Given this list of marker genes RHOQ, FSHB, ECE1, BST1, XAF1, SCN1A, GUCY2C, PPIH, ESS2, HEATR6, IGFBP7 (NCBI Gene Id 3490), MTDH, CA4, CACNA1H, AIF1, ANKRD12, SUMF1, ULBP1, THAP4, PI4K2B, AGTRAP, PSMD10, RB1, ERGIC1, LYNX1, CCND2 (NCBI Gene Id 894), ANKRD50 (NCBI Gene Id 57182), TIMM8B, CFP, RTN4RL1, TBC1D12, PPM1J, MTLN, IFNLR1, GTPBP3, RNF125, PPP1R15A, CD177, RIPOR3, MEX3B, PIGZ, POLRMT, RUNDC3B, CCDC88B, ETV1, NRIP1, FYB1 (NCBI Gene Id 55458), TNFSF14, SLC39A4, SPTA1, COL4A1 (collagen type IV alpha 1 chain), NTAN1, VAMP7, IGLC7, NDUFA6, SESN3, ORM2, FKBP7, IL12A, CFH, ECPAS, HNF4G, H2AJ, CYB5R3, FLNC, HDAC9, TMEM60, CHST7, TEX19, ABHD17B, COL14A1, AMMECR1L (NCBI Gene Id 83607), CDK13, TNFSF13B, TMEM223, DECR2, LRMDA, RTRAF, GCNT2, ZCRB1, ALDH1L2, NIPSNAP1, DYNLT1 (dynein light chain Tctex-type 1), DCN, SRGAP1, AMACR, HRG, HS6ST2, ZMYND15, TMEM45A, DTX2, FKBP14, STAB1, VGLL3, CXCL6, RPL22, ENO1, FCGR2B (Fc gamma receptor IIb), MYOM3, PBXIP1, ST3GAL1, C3, C3orf70, GBP6, C19orf81, RETN, COX19, CRABP1, MKI67, AZIN2, IRS2, PIK3CG, ITGA7, ANKRD37, HOXB4, ZNF654, ROBO1, CCSER1, TMEM239, SLPI (NCBI Gene Id 6590), SLC30A9, SMOX, ADAM9 (ADAM metallopeptidase domain 9), COX8A, MAGED1, PTPN2, MFSD2B, XKR8, CHCHD7, SLC1A2, PM20D1, SDF4, COL1A1, HK2, SCN7A, CD72, DOK5, LPCAT2 (lysophosphatidylcholine acyltransferase 2), TTC13, RPE, ROM1, TMEM125, MMP10, EGLN3, TMEM119, MRPS24, PRSS23, CFLAR, CPD, ADGB, H1-10, NCAM1, PYCR2, ISG15, ZNF322, THADA, IFT27, MYL6, RNF114, REEP1, GREM2, CKS2, PLAT, SCARF1, GALNT2, CST7, SAPCD1, CCN3, VPS36, EAF2, AVPI1, C1QB, RPL22L1, CDC16, TNNC1, SLC24A3, SAA2, UNC5C, MEDAG, RPS25, CDH26, STAT1, NDUFA2, SNAPC5, SCRN3, F13A1, SLC25A18, HOOK2, SLC35F1, SLC15A3, FSTL1, ZBTB8OS, ZFPL1, GNAZ (NCBI Gene Id 2781), TMEM33, ZNF808, EIF4E3, KIAA1549, IL4R, PICALM, here is a description of the gene set: Human Gene Set: GSE2585_CTEC_VS_THYMIC_MACROPHAGE_UP from publication Derbinski J, Gäbler J, Brors B, Tierling S, Jonnakuty S, Hergenhahn M, Peltonen L, Walter J, Kyewski B (PMID 15983066) Genes up-regulated in cortical thymic epithelial cells (cTEC) versus thymic macrophages. studied in species Homo sapiens Gene expression in different thymic stromal cells and subsets thereof was analyzed in 6-12 week old wild type (C57BL/6) and Aire knock-out (mixed background) mice. Thymic stromal cells were purified by sequential enzymatic digestion (collagenase, collagenase/dispase and trypsin) followed by gradient centrifugation and FACS sorting. Sort criteria were as follows: dendritic cells (CD11c+, F4/80 -), macrophages (F4/80+, CD11c-), cTECs (CD45–/lo, CDR1/Ly51+, Ep-CAM+) and mTECs (CD45–/lo, CDR1/Ly51–, Ep-CAM+). mTECs of wild-type and Aire knock-out mice were further subdivided according to CD80 expression levels. For microarray analysis total RNA from thymic stromal cell samples of two independent experiments was pre-amplified and biotinylated by two rounds of cDNA synthesis and in vitro transcription. Fluorescence readings were evaluated by using Microarray Suite 5.0 software.